Given this list of marker genes Sppl2b, Sppl3, H13, Sppl2c, Psen1, Sppl2a, Psen2, Ncstn, here is a description of the gene set: Catalysis of the hydrolysis of nonterminal peptide bonds in a polypeptide chain, occurring within a membrane. Mouse Gene Set: GOMF_ASPARTIC_ENDOPEPTIDASE_ACTIVITY_INTRAMEMBRANE_CLEAVING species: Mus musculus